The following is a description of a gene set: Mouse Gene Set: GOBP_THALAMUS_DEVELOPMENT The process in which the thalamus changes over time, from its initial formation to its mature state. species: Mus musculus, and this is the list of marker genes: Ncam1, Tal2, Olig2, Ptchd1, Gbx2, Shh, Ncor1, Lrp6, Mecp2, Ogdh, Foxb1, Smo, Atp1a3, D130043K22Rik, Chrnb2, Uqcrq